Given this list of marker genes Drap1, Hdac2, Mxd1, Myc, Lin54, Foxo3, Tbx15, Bin1 (bridging integrator 1), Dr1, Ctnnbip1, Bmyc, Max, Hdac5, Lin52, Etv3, Ctnnb1, Tbx18, Ddx20, here is a description of the gene set: Mouse Gene Set: GOCC_RNA_POLYMERASE_II_TRANSCRIPTION_REPRESSOR_COMPLEX A protein complex, located in the nucleus, that possesses activity that prevents or downregulates transcription from a RNA polymerase II promoter. studied in species Mus musculus